Given this list of marker genes C4BPB, CR2, C4BPA, SUSD4, CD46, CR1L, TREM2, CR1, here is a description of the gene set: studied in species Homo sapiens Any process that modulates the frequency, rate or extent of the classical pathway of complement activation. Human Gene Set: GOBP_REGULATION_OF_COMPLEMENT_ACTIVATION_CLASSICAL_PATHWAY